Given this list of marker genes Slf2, Ddr2, Pkp3, Ccne1, Plcg2, Cdc73 (NCBI Gene Id 96910), Mad2l1, Camk2b, Stra8, Apex1, Rhno1, Med1, Gen1 (NCBI Gene Id 209334), Cdc25b, Ccnd2, Cep120, Ooep, Sh2b1, Prdm9, Stxbp4, Pebp1, Rock2, Pkn2, Dazl, Cdc42, Pagr1a, Vps4b, Aurka, Azin1, Ins2, Lmnb1, Tgfb1, Tgfa, Aif1, Mrgprb1, Cdc20, Ereg, Tpr, Ccne2, Cdk1, Mepce, Ncapd3, Tbx1, Sass6, Hnrnpu, Cenpj, Lsm10, Poc1b, Aurkb, Il1b, Rdx, Cyp1a1, Anp32b, Poc1a, Wiz, Paf1, Kat2b, Msx2, Exoc7, Hyal1, Igf1, Drd2, Ncapg2, Smarcd3, Hspa2, Csf1r, Fgfr1, Lrp5, Tert, Npr2, Fgf8, Edn1, Piwil2, Tas1r2, Adamts1, Ccnd1 (cyclin D1), Rad51ap1, Cdca8 (NCBI Gene Id 68105), Ube2b, Ube2c, Prkce, Tnf, Lef1, Mtbp, Plk4, Ino80, Fam83d, Tas2r102, Phb2, Pbx1, Mir124a-3, Bub1, Il1a, Sox15, Smc4, Anapc7, Rxfp3, Knl1, Gpsm2, Ezh2, Lsm11, Mta3 (metastasis associated 3), Ccn2, Cdc14b, Rad18, Map10, Cep295, App, Ddx11, Cul4a, Sstr5, Smc6, Neurog1, Rad51c, Rab11fip3, Kat5, Tbx20, Macroh2a1, Cdca5, Mad2l1bp, Stil, Anxa1, Akt1, Msx1, Npm2, Ncaph2, Ranbp1, Rb1, Ube2e2, Wnt5a, Dmrt1, Prap1, Chmp3, Ins1, Poldip2, Sfpq, Rrm1, Ppp1r35, Anapc11, Kcna5, Mir124a-1, Tmod3, Smc2, Ect2, Arf6, Rgcc, Gja1, Kmt2e, Tfdp1, Cdk4, Numa1, Ncapd2, Nsfl1c, Xrcc3, E2f7, Dync1li1, Pdgfb, Edn3, Ncaph, Pcid2, Cit, Tas2r124, Pdgfrb, Birc5, Ccnb1-ps, Cul4b, Klhl18, Dtl, Slf1, Svil (supervillin), E2f8, Wnt10b, Chek2, Larp7, Fbxo5, Cspp1, Rpl17, Rad51b, Dbf4, Tas2r121, Cdc25c, Epgn, Mapk15, Crebbp, Stox1, Ska1, Wnt4, Atad5, Rad21, Cd28 (NCBI Gene Id 12487), Kif20b, Rab11a, Adam17, Mir124a-2, Hoxa13, Cdc6, Nusap1, Anapc5, Cenpv, Cdc25a, Fen1, Met (NCBI Gene Id 194383), Racgap1, Crnn, Ankrd17, Cpsf3, Fgf10, Ccnb1, Insr, Ndc80, Ccnd3 (cyclin D3), Mad1l1, Camk2d, Dync1h1, Ddx3x, Spag5, Egfr, Sirt2, Sphk1, Cdc14a, Cenpe, Ppp1r10, Rptor, Gli1, Egf, Spast, Plrg1, Kif14, Sin3a, Ubxn2b, Mblac1, Phip (pleckstrin homology domain interacting protein), Map3k20, Becn1, Cxcr5, Brd4, Cdc23, Mdm2, Kif23, Rrm2b, Sgo2a, Plcb1, Rrm2, Incenp, Cdc7, Ccdc15, Pkp4, Trp63, Plscr1, Nudt16, Dyrk3, Smpd3, Igf1r, Meiosin, Kif3b, Npm1, Ska3, Ankrd31, Nsmce2, Rcc2, Drd3, Nup62, Kcnn4 (potassium intermediate/small conductance calcium-activated channel, subfamily N, member 4), Eif4g3, D1Pas1, Btc, Usp19, Cdc16, Smc5, Cul3, Igf2, Atrx, Rhoa, Tbx2, Wnk1, Orc1, Gipc1, Eif4g1, here is a description of the gene set: Any process that increases the rate, frequency or extent of a cellular process that is involved in the progression of biochemical and morphological phases and events that occur in a cell during successive cell replication or nuclear replication events. species: Mus musculus Mouse Gene Set: GOBP_POSITIVE_REGULATION_OF_CELL_CYCLE_PROCESS